The following is a description of a gene set: from publication Colin C, Baeza N, Bartoli C, Fina F, Eudes N, Nanni I, Martin PM, Ouafik L, Figarella-Branger D (PMID 16314830) Human Gene Set: COLIN_PILOCYTIC_ASTROCYTOMA_VS_GLIOBLASTOMA_UP Glioblastoma (GBM) is a highly malignant glioma, which has the propensity to infiltrate throughout the brain in contrast to pilocytic astrocytoma (PA) of the posterior fossa, which does not spread and can be cured by surgery. We have used Suppression Subtractive Hybridization to define markers that better delineate the molecular basis of brain invasion and distinguish these tumor groups. We have identified genes expressed in PA versus GBM and genes expressed in GBM versus PA. Subsequent analysis identified a subset of 20 transcripts showing a common differential expression pattern for the two groups. GBM differs from PA by the expression of five genes involved in invasion and angiogenesis: fibronectin, osteopontin, chitinase-3-like-1 (YKL-40), keratoepithelin and fibromodulin. PA differs from GBM by the expression of genes related to metabolism (apolipoprotein D), proteolysis (protease-serine-11), receptor and signal transduction (PLEKHB1 for Pleckstrin-Homology-domain-containing-protein-family-B-member-1), transcription/translation (eukaryotic-translation-elongation-factor-1-alpha1) processes and cell adhesion (SPOCK1 for SPARC/Osteonectin-CWCV-kazal-like-domains-proteoglycan). The expression of these genes was confirmed by real-time quantitative RT-PCR and immunohistochemistry. This study highlights the crucial role of brain invasion in GBM and identifies specific molecules involved in this process. In addition, it offers a restricted list of markers that accurately distinguish PA from GBM. studied in species Homo sapiens Genes up-regulated in pilocytic astrocytoma compared to glioblastoma samples., and this is the list of marker genes: ATP1A2, FTH1, SOX8, DKK3, CPE, APOD, DNER, ITGA3, GFAP, RASSF2, GLUL, NLGN2, HTRA1, SCRG1, PLEKHB1, TSPAN7, RTN3, HLA-A, ANGPTL2, TF, GALNT13, SCD, SPOCK1, OLIG2, SERPINA3, SOX10, SOD2, GPRC5B, PDZD2, EEF1A1, PLA2G2A, TNFRSF21, SERPINE2, ALDOC